The following is a description of a gene set: Combining with a neuropeptide to initiate a change in cell activity. Human Gene Set: GOMF_NEUROPEPTIDE_RECEPTOR_ACTIVITY studied in species Homo sapiens, and this is the list of marker genes: GPR83, SSTR3, SSTR1, CCKBR, GRPR, KISS1R, TACR1, BRS3, NPFFR2, HCRTR2 (NCBI Gene Id 3062), NPBWR2, PRLHR, GPR37, NTSR2, SSTR4, SORCS2, NPY1R, MC2R, SORCS1, QRFPR, SSTR2, MCHR1, NPY6R, NPY2R, SSTR5, PROKR1, GPR139, NPY4R2, OPRM1, NMUR1, GAL, NPBWR1, TACR2, GPR171, NPSR1, NPFFR1, GALR3, NMUR2, NPY5R, GPR143, NPY4R, TACR3, PROKR2, GALR2, GALR1, SORCS3, NTSR1, NMBR